Given this list of marker genes Fcgr1, Btk, Fcer1a, H2-T23, Ighg2b, Ccr7, C3, Fcer1g, Park7, Fcgr3, Cnr1, Ighg1, Zp3, here is a description of the gene set: species: Mus musculus Any process that activates or increases the frequency, rate, or extent of an acute inflammatory response to an antigenic stimulus. Mouse Gene Set: GOBP_POSITIVE_REGULATION_OF_ACUTE_INFLAMMATORY_RESPONSE_TO_ANTIGENIC_STIMULUS